The following is a description of a gene set: studied in species Homo sapiens An abnormal increase in the size of the kidney. Human Gene Set: HP_ENLARGED_KIDNEY Enlarged kidney, and this is the list of marker genes: DICER1, GNPTAB, PRKAG2, DNAJB11, GANAB, MYRF, ADNP, IFT140, AKT1, ANKS6, TCTN2, G6PC1, NEK8, INSR, NAA10, ZIC3, SLC29A3, DZIP1L, CPT2, NPHP3, PKHD1, FAH, WT1 (WT1 transcription factor), ALG5 (ALG5 dolichyl-phosphate beta-glucosyltransferase), SLC37A4, DYNC2H1, IGF2, TULP3, CILK1, KCNQ1, FANCB, VPS45, PKD2, BICC1, PIK3CA, CDKN1C, INVS, KCNQ1OT1, VPS33A, ALG9, BMPER, PKD1, TRPV6, GPC3, CD81, SAA1 (serum amyloid A1), GPC4, FIBP